The following is a description of a gene set: Human Gene Set: HP_GIANT_SOMATOSENSORY_EVOKED_POTENTIALS An abnormal enlargement (i.e. increase in measured voltage) of somatosensory evoked potentials. species: Homo sapiens Giant somatosensory evoked potentials, and this is the list of marker genes: MARCHF6, NHLRC1, EPM2A, SEMA6B, STARD7, SAMD12